Given this list of marker genes Defb6, Osbpl2, Sdcbp (syndecan binding protein), Pard3, Syt5, Twf1, Dnm2, Mark1, Amer2, Cgas, Gsdme, Hip1r, Snx20, Plcb1, Gsdmd, Chmp3, Kcnj2, Commd1, Myo1g, Gramd2a, Gsdmc3, Hcn1, Pfn2, Krit1, Capg, Anxa2, Kcnj1, Gsdma3, Syt7, Jph2, Actn2, Sestd1, Rab35, Apba1, Tirap, Exoc7, Dnm1, Asap1, Defb4, Syt3, Vil1, Mapkap1, Gsdmc, Svil, Defb8, Ttpa, Syt1, Rs1, Amer3, Pla2g4e, Mtss2, Adap2, Rag2, Phlda3, Picalm, Gsdmc2, Dab2, Plcz1, Defb5, Pfn1, Snap91, Syt9, Plekha4, Syt10, Exoc1, Alox15, Amer1, Sytl2, Defb3, Washc2, Gsn, Anxa8, Vill, Sh3pxd2a, Scin, Tulp1, Fcho2 (FCH domain only 2), Fzd7, Snx21, Kcnj3, Ldlrap1, Sdcbp2, Gsdma, Gsdmc4, Twf2, Obscn, Gsdma2, Kcnq1, Myo1b, Snx18 (sorting nexin 18), Defb7, Avil, Frmpd4 (NCBI Gene Id 414749), Flii, Rph3a, Cadps, Plcd1, here is a description of the gene set: Binding to phosphatidylinositol-4,5-bisphosphate, a derivative of phosphatidylinositol in which the inositol ring is phosphorylated at the 4' and 5' positions. Mouse Gene Set: GOMF_PHOSPHATIDYLINOSITOL_4_5_BISPHOSPHATE_BINDING studied in species Mus musculus